Given this list of marker genes RSPO2, WNT3, TBX5, CDH11, TBX4, here is a description of the gene set: species: Homo sapiens Amelia Congenital absence (aplasia) of one or more limbs. Human Gene Set: HP_AMELIA